Given this list of marker genes Alox12, here is a description of the gene set: studied in species Mus musculus Reactome Pathway: Synthesis of Hepoxilins (HX) and Trioxilins (TrX) electronically inferred by orthology from the curated human pathway This event has been computationally inferred from an event that has been demonstrated in another species.<p>The inference is based on the homology mapping from PANTHER. Briefly, reactions for which all involved PhysicalEntities (in input, output and catalyst) have a mapped orthologue/paralogue (for complexes at least 75% of components must have a mapping) are inferred to the other species. part of: Arachidonate metabolism